The following is a description of a gene set: The retrograde movement of substances within the Golgi, mediated by COP I vesicles. Cis-Golgi vesicles are constantly moving forward through the Golgi stack by cisternal progression, eventually becoming trans-Golgi vesicles. They then selectively transport membrane and luminal proteins from the trans- to the medial-Golgi while leaving others behind in the trans-Golgi cisternae; similarly, they selectively move proteins from the medial- to the cis-Golgi. Mouse Gene Set: GOBP_RETROGRADE_TRANSPORT_VESICLE_RECYCLING_WITHIN_GOLGI studied in species Mus musculus, and this is the list of marker genes: Cog3 (component of oligomeric golgi complex 3), Cog7, Cog6, Cog5 (component of oligomeric golgi complex 5), Cog4, Golga5, Cog8, Cog1, Cux1, Cog2